Given this list of marker genes AGXT, AGXT2, DAO, GPT2, GPT, here is a description of the gene set: Human Gene Set: GOBP_ALANINE_METABOLIC_PROCESS The chemical reactions and pathways involving alanine, 2-aminopropanoic acid. studied in species Homo sapiens